Given this list of marker genes CCNL1, RABGEF1, XRN1, PCCB, PLA1A, ARL4A, LPAR1, ABI3BP (ABI family member 3 binding protein), RBMS1, PIP5K1A, LONP2, SAV1, COX18, GLYCTK, AP3D1, IFNAR1, ATG4D, EEIG1, NDUFA9, CD163, NRROS, PDGFA, GPR88, KCNQ2, SAMD4A, HBEGF, NPY5R, TBRG1, CLTB, SCML4, RAB3C (NCBI Gene Id 115827), HAL, EYA4, BCL9, SRGAP2, PIGX, CCT5, EFHD1, KRT2 (keratin 2), FRMD6, F10, CLSTN1, TBCA, BHLHE41, ZDHHC5 (zinc finger DHHC-type palmitoyltransferase 5), PI4K2A, F7, VPS28, PTRH1, MYL6, TBXAS1, NDUFV3, RPS6KA2, GAPDHS, ARHGAP6, PMP22, TSPAN12, CRYBG3, LY6G6D, NFKB1, FABP3, SLC30A3 (solute carrier family 30 member 3), CS, DSTN, SUB1, FHL2, FOXP1, MAB21L2, CCDC80, PTH, KLHL11, SPTLC2, MEN1, RRAS2, P2RY14, STMN1, RANBP1, MATN2, S100G, GJB2, SHROOM3, PARP12, GPR162, NOC4L, SPTBN2, TMEM243 (NCBI Gene Id 79161), MAN1A1, F13A1, IL23A, SYT12 (NCBI Gene Id 91683), SIAH1, RBM3, NSDHL, DAGLB, TPBG, LYPD8, ACE2, NECTIN2, SAPCD1, CCR1, TMEM135, FCRLA, ADA, SPAG5, HMGCS1, PPP4C, TLR6, TENT5C, PRKX, MAP2K4, UBE2D1, CHRND, CLN5, RASA4, OXCT1 (NCBI Gene Id 7898), CYP26A1, CCNL2, ANKRD44, RUFY3, TBC1D15, NME1, NUP93, THOC6, TC2N, CLK3, C2orf76, FOXH1, KCNA7, ARF6, LRRN1, BICC1, KDM5C, EDN1, ALYREF, PLS1, CHST4, SNN, MTM1, FXYD1, UQCRFS1, MITF, KAZN, ADGRA3, KATNA1, TRAF5, SEZ6, RHOC, RAB9A, CMTM3, HOMER3, ADK, NAA11, RFK, NDE1, IL18, NCK1, ATP5MC1, XCR1, ELAVL2, SLC25A22, CDH15, KRT85, EMP1, MARCHF5, LCN8, GFI1B, MT2A, GNG3, SBDS, PTPRR, GTSF1L, TMT1B, NRK, LGALS8, CYP4A22, SOD3, WNT7B, BFAR, MRC2, NODAL, S100A10, UTP3, OTUD5, TRIM69, SEPTIN6, SORCS3, PHLDA2, INSM1 (INSM transcriptional repressor 1), ECE2, ANKRD22, OSGIN2, HOXA11, MPP4, ITLN1, COL5A3, EMP3, CAMKK2, FTCD, KATNBL1, SRD5A2, here is a description of the gene set: from publication Amit I, Garber M, Chevrier N, Leite AP, Donner Y, Eisenhaure T, Guttman M, Grenier JK, Li W, Zuk O, Schubert LA, Birditt B, Shay T, Goren A, Zhang X, Smith Z, Deering R, McDonald RC, Cabili M, Bernstein BE, Rinn JL, Meissner A, Root DE, Hacohen N, Regev A (PMID 19729616) Genes up-regulated in comparison of dendritic cells (DC) stimulated with CpG DNA (TLR9 agonist) at 4 h versus those stimulated with CpG DNA (TLR9 agonist) at 24 h. mouse primary BMDCs were stimulated with tlr ligands and gene expression changes were profiled on Affymetrix arrays studied in species Homo sapiens Human Gene Set: GSE17721_4_VS_24H_CPG_BMDC_UP